Given this list of marker genes Fes, Klrc3, Slamf8, Vpreb3, Mir181b-2, Mir301, Kmt5c, Nfkbiz, Clec2d, Lgals3, Tlr9, Kmt5b, Serpinb9f, Msh2, Klre1, Wnt5a, Il6, Sphk2, Il4i1, Fut7, Ddx1, Ptprc, Il5, Cd81, Sema7a (NCBI Gene Id 78407), Fcgr1, Ifnb1, Exosc3, Azgp1, Zpbp2, Lacc1, Cd226, Il13ra1, Colec10, Ppp3cb, Hspd1, Vsir, Zfp683, Il12b, Foxf1, Tgfb1, Rigi, H2-M10.1, Gab2 (NCBI Gene Id 14389), Ffar2, B2m, Il20rb, Dpp4, Brd4, Tril, Axl, Fcgr2b, Pagr1a, Cd40, Klri1, Serpinb9e, Shld2, Rbp4, Lamp1, Sirt1, 2410137M14Rik, Serping1, Ccr6, Scimp, Stat6, Fcer2a, Cd177, H2-M9, Lgals9, Prg2, Il13ra2, Hlx, Il12a, Klrc2, Dhx58, Enpp3, Il17f, Evpl, Gprc5b (G protein-coupled receptor, family C, group 5, member B), Cd300a, Atg9a, Ccl19, Panx1 (pannexin 1), Ppl (periplakin), Pomc, Rara, Zfp35, Stxbp1, H2-Q7, H2-M3, H2-M2, H2-DMb2, Cd160, Ephb2, Ins1, Il18, Shld3, Tnfsf4, Mavs, Arrb2, Tnfsf18, Acp5, Cd274, Slamf6, BC037156, Gimap5, Pglyrp4, Havcr2, Fcgr3, Cd22, Muc4, Irak3, Mzb1, Il1b, C4bp, Itgb2, Il33, Map3k7, Psg22, Fcnb, Cd36, Stap1, Tnfrsf14, Cd37, Dusp22, Nppa, Mr1 (major histocompatibility complex, class I-related), 6030468B19Rik, Il23a, Klhl22, Ddrgk1, H2-M10.3, Tbx21, Tap2, Pkp3, H2-Q1, Fzd5 (frizzled class receptor 5), Lypd10, Rasgrp1, Ceacam1, Appl2, Klrb1b, Cd55b, Malt1, H2-K1, Ncr3-ps, Mif, Prkaa1, H2-D1, Dnajb9, H2-T15, Cxcl1, Tnf, Gimap3, Slc15a4, Lgals1, Spn, Cd28, P2rx7, Cd40lg, Hpx, Hmox1, Was, H2-T5, Ripk2, Siglecg, Raet1d (retinoic acid early transcript delta), Cd5l, Zp3r, Lilrb4b, Ighm, Klrh1, Dnase1l3, Irf1, Mir181b-1, H2-T22, Susd4, H2-M10.4, Ncf1, Prkdc (protein kinase, DNA activated, catalytic polypeptide), Kit, Zbtb1, Vsig4, Vav1, Ddx21, Traf6, Syk, Il4ra, Spon2, Mlh1, Ivl, Hk1, Cfp, Irf5, Litaf, Adora2b, Pdcd1, Cr2, A2m, Tgfb2, Card9, Pnp, Trim6, Pf4, Cxcl5, Rtn4, H2-M11, Klrb1c, Nppc, H2-Q10, Serpinb9g, Ripk3, H2-Q2, Serpinb9d, H2-T23, Arg1, Clec7a, Sh2d1a, H2-M10.2, Klrb1, Hfe, Itgb2l (integrin beta 2-like), Lep, Klrk1, Foxp1, Phb1, Ahr, Stat5a, Slamf1, Smad7, Cd244a, Cuedc2, Tnfaip3, Gpi1, Ffar3, Brd2, H60c, Cd46, Pla2g3, Mill1, Il18r1, Vamp8, Pla2g5, Il7r, Rabgef1, Rc3h2, Cd1d1, Gata1, Hspa8, Fadd, Il1r1, Pglyrp1, Tnfsf13, Nlrx1, Ankrd17, Myo18a, Stx4a, Tlr7, H2-M5, Cfh, Btk, Klrb1a, Ticam1, Nod1, H60b, Arid5a, Klk7, Mad2l2, Pdpk1, Rsad2, Ywhag, Il2rg, Zp3, Angpt1, H2-T24, Crk, Epx, Rasgrp4, Trex1, Casp4, Igf2, H2-Ea, Spi1, Ptpn6, H2-M10.6, Ccl20, Crtam, Cd74, Slc22a13, Bcr (BCR activator of RhoGEF and GTPase), Shld1, Apoa2, H2-M10.5, Ccr2, Ufl1, Cd27, Socs5, Rc3h1, Pram1, F2rl1, Cd55, Masp1, Foxp3, Cd84, Ighg2b, H2-Q4, Phb2, Tyrobp, Fcer1g, Nlrp3, Klri2, Il17a, Il21, H2-DMb1, Nsd2, Loxl3, Tek, Il4, Stxbp2, Cd1d2, Inava, Grb2, Laptm5, H2-M1, Serpinb9c, Cd86, Tap1, Nr4a3, Unc13d, Klrd1, Lilrb4a, Myd88, Cd96, Mbl2, Opa1, Traf2, Anxa1, Snx4, Ulbp1, Ddx60, Atg5, Clnk, Trpm4, Fcer1a, Hmces, Foxj1, Klk5, Zc3h12a, Cd59a, Pld2, Htr2a, Crhr1, Mir324, Nckap1l, Gata2 (NCBI Gene Id 14461), Pycard, Ins2, H2-T13, C1qbp, Pgc, Ptpn22, Inpp5d, Pvr, Paxip1, Cadm1, Mir326, Shb, Exosc6, Rac2, Cgas, Il13, Pck1, Calhm6, Zbtb7b (NCBI Gene Id 22724), Ager, Parp3, Grn, Colec11, Ccl2, Itgam, Xcl1, Serpinb9b, Galnt2, Tnfrsf4, Rif1, Pms2, Nfkbid, Nectin2, Tirap, Tlr3, Abr, Gfer, Stat5b, Fgr, Nod2, S100a9, Cd59b, Cfhr4, Twist2, C3, Tlr4, Atad5, Pkn1, D6Wsu163e, Tnfrsf1b, Hmgb1, Trp53bp1, Rps19, Tfrc, Cd24a, Xbp1, Nectin4, Fbxo38, Ighg1, Fer, Adora3, Tlr2, Ep300, Ptafr, Serpinb9h, Ndfip1, Lypd11, Pik3r6, Clec12b, Ifng, Serpinb9, Il18rap, Tmbim6, Lbp, Il27ra (interleukin 27 receptor, alpha), Dusp10, Il27, Stx7, Ap1g1, Mapkapk2, H2-T3, Plcg2, Ascl2, Clec4g, Tgfb3, Fgl2, Bcl6, Casp1, Cd80, Il2, Trem2, Sh2d1b1, Cx3cr1, Lag3, Supt6, Usp17le, Lyn, Ms4a2, Bst2, Gata3, Il10, Ube2j1, Ccr7, Klrc1, Cyrib, Aplf, Dnase1 (deoxyribonuclease I), Raet1e, Prkcz, Dennd1b, Pglyrp2, Twist1, H2-Q6, Pglyrp3, Cd69, Dhx36, Jak3, Clcf1, Lta, Apoa1, Appl1, Klrb1f (killer cell lectin-like receptor subfamily B member 1F), Sash3, Cr1l, Sh2d1b2, here is a description of the gene set: Mouse Gene Set: GOBP_REGULATION_OF_IMMUNE_EFFECTOR_PROCESS Any process that modulates the frequency, rate, or extent of an immune effector process. studied in species Mus musculus